The following is a description of a gene set: Human Gene Set: MCBRYAN_TERMINAL_END_BUD_DN from publication McBryan J, Howlin J, Kenny PA, Shioda T, Martin F (PMID 17486082) The 'TEB profile genes': down-regulated during pubertal mammary gland development specifically in the TEB (terminal end bud) structures. Expression microarray analysis identified over genes regulated during puberty in the mouse mammary gland. Most prominent were genes whose expression increased in parallel with pubertal development and remained high thereafter. Members of the Wnt, transforming growth factor-beta and oestrogen-signalling pathways were significantly overrepresented. Comparison to expression data from CITED1 knockout mice identified a subset of oestrogen-responsive genes displaying altered expression in the absence of CITED1. Included in this subset are stanniocalcin2 (Stc2) and amphiregulin (Areg). Chromatin immunoprecipitation revealed that ERalpha binds to oestrogen response elements in both the Stc2 and Areg genes in the mammary gland during puberty. Additionally, CITED1 and ERalpha localize to the same epithelial cells of the pubertal mammary gland, supporting a role for interaction of these two proteins during normal development. In a human breast cancer data set, expression of Stc2, Areg and CITED1 parallel that of ERalpha. Similar to ERalpha, CITED1 expression correlates with good outcome in breast cancer, implying that potential maintenance of the ERalpha-CITED1 co-regulated signalling pathway in breast tumours can indicate good prognosis. species: Mus musculus, and this is the list of marker genes: LCK, PHGDH, GSN, ETS1, CORO1A, NRIP1